The following is a description of a gene set: Mouse Gene Set: GOBP_HIPPOCAMPUS_DEVELOPMENT species: Mus musculus The progression of the hippocampus over time from its initial formation until its mature state., and this is the list of marker genes: Ezh2, Uqcrq (ubiquinol-cytochrome c reductase, complex III subunit VII), Id4, Nr2e1, Btg2, Hdac1, Kirrel3, Srf, Sct, Fgf13, Mecp2, Epha5, Kcnq2, Kif14, Nf2, Drd1, Mme, Fez1, Crkl, Zic1, Lhx5, Atp2b4, Lef1, Pten, Cdk5r1, Zic3, Neurod1, Bbs4, Nr4a3, Xrcc1, Xrn2, Mkks, Fezf2, Kif3a, Crk, Hdac2, Pomgnt1, Nefl, Pomt2, Trp73, Vps13b, Dlx1, Htr5a, Mas1, Tsc1, Bbs2, Emx2, Uba6, Smo, Atg16l1, Atat1, Mdk (midkine), Alk, Ywhae, Usp9x, Neurod6, Ppp1r9b, Wnt3a, Fbxo41, Casp3, Cdk5r2, Kcna1, Gsk3b, Pianp, Sema6b, Dclk2, Dab1, Plxna3 (plexin A3), Srd5a2, Eif2b5, Nkx2-1, Lmx1a, Abcc1, Ogdh, Tuba1a, Lypd6, Tsku, Scn2a, Fxr1, Zeb2, Nfix, Rara, Csf1r, Fxr2, Bcan, Dcx (doublecortin), Ncoa1, Cdk5, Ptprs, Bloc1s6, Kdm6b, Large1, Reln, Anxa3, Dlx2, Pafah1b1, Zbtb18, Bbs1, Tmem108, Slc32a1, Gli3, Mfsd2a, Lrp8, Prox1